Given this list of marker genes IL1R1, CCL23, C5, AOAH, CCR2, PTAFR, ORM1, ADORA2A, BDKRB2, CCL21, CXCR2, CXCL1, CEBPB (NCBI Gene Id 90277), TPST1, CCL19, ABCF1, CXCL13, CXCL10, CYBB, IL1RAP, CCL18, LY86, CCR1, CXCR4, S100A9, SAA1, FPR1, CD40, CXCL8, FPR2, CXCL5, IL1B, TLR2, CCL4, CXCL9, TIRAP, ANXA1, C3, CX3CL1, CCR5, PTGS2, TLR1, AOX1, BCL6, PLA2G7 (NCBI Gene Id 7941), ALOX5 (arachidonate 5-lipoxygenase), ALOX15, AGER, AOC3, C3AR1, S100A12, CCL7, CCL3, FN1, MGLL, CCL20, CCL17, ALOX5AP, NMI, LY75, LYZ, CCL8, AIF1, NFKB1, IL1A, CXCL12, CXCL6, CCL11, ADORA1, IL9, TLR3, CXCL14, PTX3, CD14, NFATC4, CCL13, CXCL2 (C-X-C motif chemokine ligand 2), CCL2, CXCL11, FOS, C4B, here is a description of the gene set: Inflammatory response. Human Gene Set: MODULE_76 studied in species Homo sapiens